The following is a description of a gene set: Human Gene Set: GOBP_CO_TRANSCRIPTIONAL_MRNA_3_END_PROCESSING_CLEAVAGE_AND_POLYADENYLATION_PATHWAY species: Homo sapiens Any process involved in transcription termination-coupled 3' processing of RNA polymerase II mRNA transcripts by the 3' end cleavage and addition of a poly(A) tail., and this is the list of marker genes: CSTF3, PAPOLA, CPSF6, TUT1, NUDT21, CPSF7, CPSF3, SSU72, PCF11